Given this list of marker genes AGAP4, FBXL12, PRKCSH, LZTR1, MYO5A, PRKACA, MUSK, ATL2, NIPSNAP3B, MAFB, PATZ1, MIEF1, UVRAG, MYO7A, FNTA, GIMAP6, FKBP1A, SIRT6, TRBC1, ITGA4 (integrin subunit alpha 4), PPIG, MS4A6A, FGL2, ATM, HMGXB3, CCR2, RUNX1, CD86, TRAT1, GLRX, here is a description of the gene set: Asbestos is a pulmonary carcinogen known to give rise to DNA and chromosomal damage, but the exact carcinogenic mechanisms are still largely unknown. In this study, gene expression arrays were performed on lung tumor samples from 14 heavily asbestos-exposed and 14 non-exposed patients matched for other characteristics. Using a two-step statistical analysis, genes were revealed that could differentiate the tumors of asbestos-exposed from those of non-exposed patients. To identify asbestos-associated regions with DNA copy number and expressional changes, the gene expression data were combined with comparative genomic hybridization microarray data. As a result, a combinatory profile of DNA copy number aberrations and expressional changes significantly associated with asbestos exposure was obtained. Asbestos-related areas were detected in 2p21-p16.3, 3p21.31, 5q35.2-q35.3, 16p13.3, 19p13.3-p13.1 and 22q12.3-q13.1. The most prominent of these, 19p13, was further characterized by microsatellite analysis in 62 patients for the differences in allelic imbalance (AI) between the two groups of lung tumors. 79% of the exposed and 45% of the non-exposed patients (P=0.008) were found to be carriers of AI in their lung tumors. In the exposed group, AI in 19p was prevalent regardless of the histological tumor type. In adenocarcinomas, AI in 19p appeared to occur independently of the asbestos exposure. studied in species Homo sapiens Genes negatively correlated with the asbestos exposure of lung cancer patients. Human Gene Set: WIKMAN_ASBESTOS_LUNG_CANCER_DN from publication Wikman H, Ruosaari S, Nymark P, Sarhadi VK, Saharinen J, Vanhala E, Karjalainen A, Hollmén J, Knuutila S, Anttila S (PMID 17297452)